The following is a description of a gene set: studied in species Homo sapiens Human Gene Set: GOBP_REVERSE_CHOLESTEROL_TRANSPORT The directed movement of peripheral cell cholesterol, cholest-5-en-3-beta-ol, towards the liver for catabolism., and this is the list of marker genes: CETP (NCBI Gene Id 1071), CES1, MIR144, MIR19B1, APOM, ABCG1, LIPG, SCARB1, APOE, APOA1, CLU, ABCA1, LCAT, MIR33A, LRP1, ABCA5, APOA2, APOC2, LIPC, APOC3, APOA4